Given this list of marker genes Pinx1, Kras, Flt3, Ptch1, Tsc1, Prdm2, Foxo3, Cdkn2a, Tnk1, Mad1l1, Atad5, Trp73, Msh2, Tusc2, Cdkn2c, Prdx1, Rbm38, Htatip2, Fdxr, Trp53, Mdm2, Cdkn1a, Hras, Trp53bp2, Bub1b, Met, Prkar1a, here is a description of the gene set: Mouse genes annotated to increased hemangiosarcoma incidence (MP:0003667) retrieved from the Mouse Genome Informatics database via MouseMine species: Mus musculus from publication Motenko H, Neuhauser SB, O'Keefe M, Richardson JE (PMID 26092688) Mouse Gene Set: MP_INCREASED_HEMANGIOSARCOMA_INCIDENCE